The following is a description of a gene set: Mouse Gene Set: GOBP_NEGATIVE_REGULATION_OF_ENDOPLASMIC_RETICULUM_UNFOLDED_PROTEIN_RESPONSE Any process that stops, prevents or reduces the frequency, rate or extent of endoplasmic reticulum unfolded protein response. studied in species Mus musculus, and this is the list of marker genes: Ptpn1, Wfs1, Ufl1, Atad3a, Akt1, Abca7, Hspa5, Nck2, Xbp1, Nck1, Bfar, Ddrgk1, Akt2, Igtp, Akt3, Atf6b, Pdia6, Crebrf, Dnajb9